The following is a description of a gene set: species: Mus musculus part of: Sphingolipid metabolism electronically inferred by orthology from the curated human pathway This event has been computationally inferred from an event that has been demonstrated in another species.<p>The inference is based on the homology mapping from PANTHER. Briefly, reactions for which all involved PhysicalEntities (in input, output and catalyst) have a mapped orthologue/paralogue (for complexes at least 75% of components must have a mapping) are inferred to the other species. Reactome Pathway: Sphingolipid catabolism, and this is the list of marker genes: Aldh3b2, Aldh3b1, Plpp1, Sgpl1, Sgpp1, Sgpp2, Plpp2